The following is a description of a gene set: Human Gene Set: GSE20715_0H_VS_6H_OZONE_LUNG_DN from publication Bauer AK, Rondini EA, Hummel KA, Degraff LM, Walker C, Jedlicka AE, Kleeberger SR (PMID 21543283) Genes down-regulated in comparison of lung tissue from wild type mice subjected to ozone for 0 h versus that from wild type mice subjected to ozone for 6 h. We previously identified toll-like receptor 4 (Tlr4) as a candidate gene responsible for ozone (O3)-induced pulmonary hyperpermeability and inflammation. The objective of this study was to determine the mechanism through which TLR4 modulates O3-induced pulmonary responses and to utilize transcriptomics to determine TLR4 effector molecules. C3H/HeJ (HeJ; Tlr4 mutant) and C3H/HeOuJ (OuJ; Tlr4 normal), mice were exposed continuously to 0.3 ppm O3 or filtered air for 6, 24, 48 or 72 hr. Affymetrix Mouse430A_MOE gene arrays were used to analyze lung homogenates from HeJ and OuJ mice followed using a bioinformatic analysis. Inflammation was assessed by bronchoalveolar lavage and molecular analysis by ELISA, immunoblotting, and transcription factor activity. TLR4 signals through both the MYD88-dependent and independent pathways in OuJ mice, which involves MAP kinase activation, NF-kappaB, AP-1, and KC. Microarray analyses identifiedTLR4 responsive genes for strain and time in OuJ versus HeJ mice (p<0.05). One significantly upregulated cluster of genes in OuJ were the heat shock proteins (Hspa1b; Hsp70), Hsp90ab1). Furthermore, O3-induced expression of HSP70 protein was increased in OuJ compared to HeJ mice following 24-48 h O3. Moreover, BAL polymorphonuclear leukocytes (PMN) and total protein were significantly reduced in response to O3 in Hspa1a/Hspa1btm1Dix (Hsp70-/-) compared to Hsp70+/+ mice (p<0.05). TLR4 signaling (MYD88-dependent), ERK1/2, AP-1 activity, and KC protein content were also significantly reduced after O3 exposure in Hsp70-/- compared to Hsp70+/+ mice (p<0.05). These studies suggest that HSP70 is involved in the regulation of O3-induced lung inflammation through the TLR4 pathway and provide evidence that HSP70 is an endogenous in vivo TLR4 ligand. studied in species Homo sapiens, and this is the list of marker genes: DRAP1, DDX3X, NUS1, MT2A, DUSP7 (dual specificity phosphatase 7), TCEAL9, PPP5C, NPR3 (NCBI Gene Id 79614), ACKR3, MRPL37, PI4K2B, ZFAND3, C6orf89, MAPRE2, RS1, STOM, MTMR1, BCL3, CEMIP2, CHEK1, MEF2B (myocyte enhancer factor 2B), PPP2R5B, MASP2, ACVR1B, CLVS1, ZBTB20, KCNK5, PELI2, IMPACT, OSMR (NCBI Gene Id 9180), TLR2, TNNT3, SLC7A6, TOP1, BCKDHA, LEPR, CEP290, PLD1, APCDD1, MARCHF6, AMACR, SHANK3, CTTNBP2NL, TSC22D1, LRRK2, POMT1, ATOH7, WDR33, NCDN, NPTXR (neuronal pentraxin receptor), RHBDL3, EFNB1, SLC10A6, NID2, SEC14L4, AFF4, YBX1, ACER2, DUSP11, CLIP4, TRAPPC3, TCERG1, SASH1, CP, CCDC102A, FSIP1 (fibrous sheath interacting protein 1), FURIN, AREG, CRY2, RAB20, SST, CD163, CCNT1, SPNS1, PHAF1, CCNT2, ABHD5 (NCBI Gene Id 51099), STX3, TBX5, COL4A3, GALM, PIGR, LPAR3, SLC6A20, YIPF7, TRIB1, STARD8, NUDT6, PRKCH, CADM3, COL16A1, NKD1, PDCD1, SPTBN2, RGS9 (NCBI Gene Id 8787), UBR2, TNS2, FNDC4, AGBL3, ELF3, SLC15A2, ZNF746, ZFP42, HP, C14orf180, PDXDC1, POR, PDK4, ID1, S1PR1 (sphingosine-1-phosphate receptor 1), MT1E, LIMCH1, PRDX6, KRTAP4-11, CLK3, TXNRD1, TXLNG, DPYSL5, NOTCH1, PER1, DUSP6, BCL2L11, STYX (NCBI Gene Id 730432), OSGIN2, FASN, SLC43A3, ITFG2, EPHA2, FGFBP1, GSN, IBTK (inhibitor of Bruton tyrosine kinase), CD14, PFKFB3 (NCBI Gene Id 5209), ACOX1, RHOC (ras homolog family member C), SPP1, NTMT1, FAM13C, TSHB, AGR3, CDYL, NAP1L1, ANKS1A, ERRFI1, RBM15, HSPG2, DPYSL4, PPIL4, MSANTD3, STBD1, TULP4, CXCL2, KHDC4, UBAP1, RIOK2, MARCKS, TSR3, ITPR3, FRMD6, LAMA5 (laminin subunit alpha 5), RCAN2, GFM1, MAT1A, REXO4 (REX4 homolog, 3'-5' exonuclease), CDK18, BRD4, NUP88, PSMD9, SPEN, TMEM135, INPP5D, TIMM23 (translocase of inner mitochondrial membrane 23), GPX2, CBR3, SLC38A2, SOCS3, SGMS1, GATAD2B, GCLC, EGLN2, RICTOR, GPX3, BGN, CDC42EP4, ACE (angiotensin I converting enzyme), KCNN3, DRD4, HES6, ALKBH4, ULK1, LPIN2, A4GALT, CPSF4, ZFP57, OSGIN1, WDR54 (WD repeat domain 54), SNRK, FSTL1, ITGA6, CXCL6